Given this list of marker genes Rims1, Slc17a7, Slc38a2, Gls, Ppfia3, Stx1a, Snap25, Ppfia1, Stxbp1, Cplx1, Ppfia4, Gls2, Slc1a7, Slc1a1, Tspoap1, Slc1a6, Unc13b, Rab3a, Arl6ip5, Slc1a3, Slc1a2, Syt1, Ppfia2 (NCBI Gene Id 327814), Vamp2, here is a description of the gene set: species: Mus musculus Mouse Gene Set: REACTOME_GLUTAMATE_NEUROTRANSMITTER_RELEASE_CYCLE Glutamate Neurotransmitter Release Cycle